Given this list of marker genes PRKCD, CD81, ITK, TNFRSF13C, RASGRP1, RFX5, CR2, MAGT1, GALC, CIITA, STIM1, ACP5, ZAP70, PNP, NFKB1, CTNNBL1, STAT3, DOCK11, SOCS1, TNFSF12, MS4A1, ADA, SASH3, CTLA4 (NCBI Gene Id 3411), KMT2D, RFXANK, IL7R, NFKB2 (NCBI Gene Id 4791), LRBA, CD19, IRF2BP2, ICOS, ARPC5, FAS, STAT1, RFXAP, LAT, FASLG (NCBI Gene Id 356), NRAS, TNFRSF13B, KRAS, KDM6A, SMPD1, TLR7, TPP2 (NCBI Gene Id 7174), ARHGEF1, CASP10, FOXP3, here is a description of the gene set: species: Homo sapiens Human Gene Set: HP_AUTOIMMUNE_THROMBOCYTOPENIA Autoimmune thrombocytopenia The presence of thrombocytopenia in combination with detection of antiplatelet antibodies.